Given this list of marker genes SMARCA2, PIK3R1, HDAC4, FLNA, TRPV4, MRPS28, KDM4B, GPC3, WAC, ERI1, TRIO, EVC, RSPRY1 (ring finger and SPRY domain containing 1), CRKL, ATP7A, TONSL, BGN (NCBI Gene Id 633), PTH1R, RMRP, HERC2, TRPS1, CAMTA1, BCR, DVL3, LTBP3 (NCBI Gene Id 4054), LMNA, COL9A2, DDR2, COL2A1, KAT6B, IGF1R, TRIP11, KDM5C, GPX4, FGD1, WNT5A, CCBE1, SH3PXD2B, HDAC6, COL11A1, IHH, KCNJ2, DVL1, ADAMTSL2, KRAS, YY1AP1, MKRN3 (makorin ring finger protein 3), GDF5, SIN3A, BRD4, SIL1, SCUBE3, MBD5, DYNC2H1, PWAR1, CUL4B, DYNC1H1, IFT80, PIGL, RBPJ, SNORD116-1, CAMK2G, COG4, INPPL1, WDR81, FGF9, SNORD115-1, NOG, CHSY1, PWRN1 (NCBI Gene Id 791114), PDGFRB, FBN1 (NCBI Gene Id 7470), TBCE (NCBI Gene Id 6905), EVC2, KLHL15, FBXO11, ANKRD11, PUF60, RNU4ATAC, PPP2R3C, DYNC2I1, FGFR1, WDR35, FGFR2, BHLHA9, CRLF1, DPM1, GPC4, MEGF8, RECQL4, TBL1XR1, ORC1, FZD2, TCF4 (NCBI Gene Id 6925), RAB3GAP2, PRKAR1A, MAPK1, RAB23, ANTXR2, NEK1, ROR2, HNRNPR, B3GLCT, MAP3K7 (mitogen-activated protein kinase kinase kinase 7), TMEM53, NPAP1, MAPRE2 (NCBI Gene Id 51683), FGFR3, COL11A2, SNIP1, MAGEL2, RAI1, SMAD4, DYNC2I2, PTDSS1, MSL3, here is a description of the gene set: studied in species Homo sapiens Human Gene Set: HP_SHORT_PALM Short palm Short palm.